The following is a description of a gene set: Genes containing one or more binding sites for (ZNF610) in their promoter regions (TSS -1000,+100 bp) as identified by GTRD version 20.06 ChIP-seq harmonization. species: Homo sapiens from publication Yevshin I, Sharipov R, Kolmykov S, Kondrakhin Y, Kolpakov F (PMID 30445619) Human Gene Set: ZNF610_TARGET_GENES, and this is the list of marker genes: PRPS2, AFDN, TMEM14C, ATAD3A, ZNF892, ZNF16, HEXA-AS1, CFAP410, FBXW8, DCAF12, FAM117B, AJUBA, MEF2A, RNF157-AS1, ARHGEF12, PNMA2, FNTB, FNBP1P1, CHMP1B, AKIRIN2, TRAF3IP2-AS1, RBBP6, RBM14, ZNF652-AS1, MLXIP, ENSG00000283674, TASOR2, TTC19 (tetratricopeptide repeat domain 19), HOXD1, CHST11, CAMK2D, RPS4X, TIGD7, STARD6, SNAP47, ILDR1, THUMPD3, RFTN1, TRMO, UBAP2L, CHPF2, IFT81, NEFM, INO80C, RAPGEF2, LINC02569, CEP135, TENM3, RPS14, WDR45B, SLC25A1, PTPN4, KLHL17, INTS14, ELAC2, ZNF846, KIF9, REPS1, FHIP1A-DT, SLC35F3, MAP3K6, VTA1, LINC01359, HSPA1B, G6PC3, MAP1LC3B, RN7SL1, MKRN1, PARP1, ENSG00000272195 (novel transcript, antisense to EFCAB2), SELENOM, PPCDC, LOH12CR2, SNORD101, SYS1-DBNDD2, P4HA1, PPP1R18 (NCBI Gene Id 170954), PLCXD1, PHF6, ABI2, TRMT12, MAP9, TOP3B, KPNA2 (karyopherin subunit alpha 2), GTF2B, ACTL6A, GTPBP3, YWHAE, KCNK5, SMARCAD1-DT, PPP4C, SUZ12, ILF3, ARRDC3-AS1, CSE1L-DT, CHMP3, TTC23L, HDAC5, ULBP1, ZNF540, HSPB6, CFL1 (cofilin 1), BUD31, PFKFB3-AS1, DVL2, FOXJ1, CYSTM1, TIMM10B, THOC1, TGFBR3, ZNF451, CPT2 (NCBI Gene Id 1376), NTMT1, RDH10, TLCD1, RNF24, PMPCB, FBXO24, DUSP6, PHF20, CREBL2, SIRT1, ZBTB2, NTAN1, EIF3D, TENM3-AS1, RPL37, KMT2B, COQ10A, KAT14, CASC9, ETFA, PCDH1, RBM8A, CRYZL1, PTPRA, BMPR1A, MTRFR, ISLR2, SENP2, MED14, NFYC, TPT1, ZMYM3, ASCC3, SAYSD1, COL4A5, SCARNA17, MED26, NIT1, TSGA10, VPS50, FHIP1A, NOVA1-DT, EXOC6B, CCDC97, RN7SL521P, ARRDC3, ETFDH, CHCT1, DFFA, SYS1, ZNF248, TOMM20, ZNF503, IER3, RCOR1, DCAF13, ITSN1, SH2D5, LIMD1-AS1, AURKAIP1, RMND1, TMEM52, ADAP2, STUB1, GAB1, TXNL1 (NCBI Gene Id 9352), TSNAX-DISC1, PHF12, RCBTB1, SMG7-AS1, RNF220, PDAP1, CHRAC1, TMEM167B (transmembrane protein 167B), USE1, ADRM1, GUCD1, VPS35L, C18orf54, MEGF8, UNC13B, THAP8, FBXL14, NUDT9, LONP1, HCG25, CLTCL1, FBN2, ZIK1, RN7SL823P, CERT1, LINC01465 (NCBI Gene Id 283416), ITFG2-AS1, CTNNB1, KCTD5, ARPP19, RN7SL832P, EFCAB7, ZMPSTE24-DT, TLE1, PLEKHG2, MOB4, ZNF503-AS2, MRPS11, DRG2, SAP18, ZNF768, AGO1, LRRC8C, CDIP1, EOGT-DT, KANSL2, PAX6, CUL4A, LINC01132, SSTR5, TFAP2A, STOX2, DPP9, NUP42, SHC4, DPY19L3-DT, PURA, METAP1, RANGRF, ZNF420, SLC39A11, ATXN2L, SRCAP, CDCA4, BLOC1S1, IRF9 (interferon regulatory factor 9), CCT5, GEMIN5, H3-3A-DT, METTL26, SF3A2, TGIF1, BRWD1, TTC4, RBFOX3, PRRC2A, SLX9, BMPR1B-DT, SEPTIN7P13, P3H2, WDR62 (WD repeat domain 62), MEF2C-AS2, FKBP4, DEDD2, MRPS35, ENSG00000266313, USP44, FOXO3, SRCIN1, H3-3B, CEP120, SMG7, IMPA2, C1GALT1C1, HIBADH, C2orf42, EIF2D, REEP5, CHRD, ZNF212, SEMA6D, GALNTL5, OXSR1, MTHFD2L, FRA10AC1, TDP2, RNASEH2C, MGME1, ABHD13, PDE4C (phosphodiesterase 4C), ENPP4, C4orf46, EEF1A1P18, BRPF1, CATSPERD, ENPP3, SNX5, LRCH4, RAB4A-AS1, ARID4B, CITED2 (Cbp/p300 interacting transactivator with Glu/Asp rich carboxy-terminal domain 2), BAP1, LINC00620, ZNF501, SDHAF4, HINT3, PLXNA4, APC, GABPB2, KDM1A, WARS2-AS1, LONRF1, ATP2B1, ZNF652, KDM4B (NCBI Gene Id 23030), DNAJC6, PSD3, P3H2-AS1, PRKAR1A, PRKCZ, ATPSCKMT, BAHCC1, TARBP2, CBX4, TPR, GOLGA4, CLEC2D, GCAT, COPS7A, PCDHGB1, MYBBP1A, TCAM1P, PRIM1, TCTN1, KLHL18, SRGAP3, KIFAP3, MMP16, JUNB, MCRIP2, CDK9, TXNIP, TTC23L-AS1, WBP4, TRAM1, ZBTB45, KCNC3, SAMD4B, ZNF239 (NCBI Gene Id 8187), TOB2, EGFEM1P, HCFC1R1, RPS17, SNRPD3, KTI12, TRIT1, POU2F1, THOC6 (NCBI Gene Id 79228), CLPP (caseinolytic mitochondrial matrix peptidase proteolytic subunit), PCLO, CNIH4, XPNPEP3, DIPK1A, TTLL1, LINC01547, PIP4K2A, ARRB2, SEPTIN7P14, PCBP2, KCNK1, MXRA7, TFB1M, MDM4, CMSS1, AHDC1, RASD1, SLC24A1, KLHDC9, UCHL5, COX16, RAB18, CCNC, PGAP1, MAPKAP1, PPP2R3A (NCBI Gene Id 5523), CCSAP, KHDC1, C2orf15, RPL7, BTAF1, KLHL20, SACM1L, SYNPO2, MPHOSPH9, DDX12P, XPO7, LINC02029, PRANCR, CYTH1, H3-3A, C1orf74, LINC01011, NADK2, PIPOX, PGGT1B, RPS26, CYB561D2, OTUD7B, PROSER3, ZNF571, MMAB, SUMO2, MRPS23, SLC39A3, DYNLT2B, EIF5A2, RAD18, HCFC1, TMEM187, PTRH2, ZNF10, RRP1B, C1orf53, UBQLN2, SCARNA2 (small Cajal body-specific RNA 2), FANCG (NCBI Gene Id 82603), MIR615, CDC37, TM9SF1 (transmembrane 9 superfamily member 1), JPX, NMRAL2P, SUZ12P1, ARHGAP10, PKN2-AS1, RGS5, PCDHGB5, ATXN3, LYSET, ZKSCAN3, CHGB, CLTA, RSU1P2, MIR4665 (microRNA 4665), REV3L, UBE2M, WAC, RIMKLB, BRF1, GNGT1, WAC-AS1, CCDC77, PDXK, RAB2B, PLEKHH1, RBM14-RBM4, CNOT6, SP7, CAPNS1, MIR3646, STUB1-DT, NEURL4, POLR3B, MTOR, ANGEL1, TMA16, HSF2BP, MGA, RO60, CCAR2, GLDC, BMPR1B, KRAS, SPAG4, FAM133B, HNRNPM, MTIF3, DLK2, RAB34, MRPL46, RCOR3, PPFIA3, SAC3D1, CECR2, PEX3, PTPRH, SLC6A9, KCTD15, RASAL2, EXO5, ETV2, PROX1, MYB, NOVA1, HNRNPKP5, GPR162, CBX3P4, CCDC157, NUP214, ATG7, ELF1, CDK4, DPYSL2, PTTG1IP, GNB2, DXO, MARCHF6-DT, WDR25, LAS1L, HECTD4, NUF2, RTN1 (NCBI Gene Id 8108), NBL1, FAM218A, HEXIM1, TMEM106C, RAB30-DT, MED23, SCAPER, LRP6, EXOC1, RERE, AIRIM, COX10-DT, TMEM116, STARD13, LNPK, SMG9, FGD4, TNFRSF10A, LINC01003, CASZ1, WARS1, XRN2, XPO6, LGMN, CNOT2, TOX4, COL4A6, BAX, DCTN2, EFCAB13, PPP2R5C, MARCHF6, ZNF740, PBX3, SRSF5, CABLES2, ANO8, ZNF827, ZFP30, XKR6, TXNRD1, ZNF526, AQP11, SYDE2, CPNE8, PDCD6P1, RNASEH2A, RNU7-27P, HNRNPLL, CTSH (cathepsin H), ATF3, CLSTN1, TFIP11, CCAR1, CEBPG, CDCA8, PCAT6, RNPS1, PPM1D, EFCAB13-DT, MRPL39, USP3-AS1, SNX15, HMG20A (high mobility group 20A), CRIM1-DT, B3GALT4, SC5D, SLC25A32, FBXL21P, LIX1L-AS1, NPRL2, STKLD1, LPAR3, TSPAN9, FBXL4, GPR6, ERBB3, PFDN2, CD320, ADAT2, NOL10, CFAP92, PGBD5, ITGA7, SEPHS1, MRPL45, VGLL4, NRAS, GNAL, RSU1, CAAP1, ZNF260, CABIN1, PFKFB3, SEMA6A, ODR4, NCBP2, ECI1, CDK18 (NCBI Gene Id 5129), STX8, TMEM222 (transmembrane protein 222), SNORA14B, CDK8, ZNF891, LMCD1, ITFG2, CYP20A1, CFLAR, POLK, ABCB10, POLR3F, AP3S2, PROX1-AS1, CCNI, ANKRD54, UST, ST13, HOOK2, ZSCAN21, EGR1, PET117, RPS6, RAB30, TSNAX, ANO6, WDR11-DT, SMARCAD1, CSPP1, COPS5, GINS3, GART (phosphoribosylglycinamide formyltransferase, phosphoribosylglycinamide synthetase, phosphoribosylaminoimidazole synthetase), EMC2, PHF8, ANKRD63, AJUBA-DT, RPS27L, TM4SF19-AS1, ENDOU, GINS4, LMTK2, CNR1, NCOA3, GGPS1, EMC3-AS1, RPS3A, WDR11, OTULIN, CFAP52, NFYB, JMJD4, CSE1L (chromosome segregation 1 like), DNAJC14, MEAK7, PKM, IMPDH1, RBM28, ACAA2, MCF2L, ANP32E, BOLA1, TMBIM4, ARFIP2, ACOT13, SMIM8, SP3, GPSM2, TP53BP2, EGLN2, SYNCRIP, UBB, ATP6V0D1, SNHG17, CDC42SE1, QRFPR, NFKBIA, GOLGA1, MBD4, TMEM179B, ZDHHC13, YTHDC2, FEM1C, RPS12, FHOD3, CSAD, RPS29, AFDN-DT, PSAP, NCAM1, ZNF862, LINC02960, ENDOG, EP300, PLEKHJ1, ARHGEF39, NFIA, PAFAH2, LIG4, MALINC1, TMEM167B-DT, CHD9, KLHL9, RANBP9, MIRLET7I, PEAK1, COX6B1, MEX3C (NCBI Gene Id 51320, mex-3 RNA binding family member C), EIF2B3, CCDC6, CTBP2, GLI3, MVK, CCDC88C, PIP4P1, IL13RA1, CEP43, ZNF384, STK19, EDN1, CHST15, GTF2IP20, BRMS1L, CPEB1, MED4 (NCBI Gene Id 51757), GALNT11, TSPAN5, THOC1-DT, SMG8, GDAP1, MTFR1, SEPTIN9, PCID2, DENR, AGO3, C14orf93, TRDMT1, ANKRD10, SND1-DT, FAM120B, ALG13, SF3A1, NQO2, ZNF398, TSC22D4, BORCS5, SNHG11, LAMP1, ZMPSTE24, UBE2Q1, IFT122, ARMT1, MIA3, ZNF75A, ENSG00000236846, TMEM198B, MIR548AL, SUPT16H, EIF1AD, SNAPC2, HTR5A, ADSS2, ISYNA1, SPRYD7, EPCIP, SND1, ZC3H11A, MIR3677HG, LMCD1-AS1, FBXO27, CACNB3, ATP6V0D1-DT (NCBI Gene Id 101927837), SYCE2, NAPRT, TFIP11-DT, ENSG00000233461, TMEM248, RTN3, METAP2, FNDC3B, PHF7, CNNM2, TENT5C-DT, ZNF425, JAGN1, SMIM2-AS1, PLD3, EMC3 (ER membrane protein complex subunit 3), POLG-DT, AGGF1, EOGT, SCAF11, CHMP7, HAGLR, ATXN10, C1orf43, CDC14A, OTULIN-DT, TECPR2, STK26, ENSG00000260830, ENSG00000187186, ETS2, DLC1, CTU1, POLG, MPPED2, TAF11, HSD17B6, PLXNA2, ENSG00000232995, UQCC4, SCAT1, SPOP, ATP1B1, DYNC2I2, ATAD2, KGD4, GTF2IP12 (general transcription factor IIi pseudogene 12), PDE8A, EXO5-DT, NUDT8, MRPL4, NR2F1, ITGB3BP, ITM2C, DPY19L3, SQSTM1, ZSWIM7, IRX3, SLC44A1, RBPJ, MRPS31P5, DLL1, ARPC1A, B4GALT1-AS1, PRELID3BP2, PPP4R3A, MZF1-AS1, MOXD1, WIPI2, MBTPS2, DMRT3, RAB4A, PBX3-DT, BANF1, JADE1, COX20, BBX, DMKN, MRPS35-DT, SUMF1 (sulfatase modifying factor 1), KMT2D, FOXJ3, ILF3-DT, TNFRSF10B, RUNDC3A-AS1, RASAL2-AS1, TEFM, LARP1, SLC36A1, TPT1-AS1, NEIL1, FBXO31, ATP2A3, C19orf47, SSTR5-AS1 (SSTR5 antisense RNA 1), LACTB2-AS1, GABARAPL1, WDR47, ZNF790-AS1, PRKCZ-DT, TSPAN5-DT, COX10, MFN2, PTPRG, RPL27, LINC02851, MAP2K5, GZF1, GBA1, ZFP69B, NCBP2AS2, SNHG22, CRIM1, PDGFA, HEXA, ERI1, DZANK1, PLEKHM1, TMEM41A, RNU4-71P, GSR, GPC6, USP32, ZNF248-AS1, RPAP3-DT (RPAP3 divergent transcript), ZNF879, PLEKHA8P1, ZBED6, KMT2A, CDKN2AIPNL, LINC01535, ENSG00000247416, PGM2L1, MEF2D, NKX2-1, DLD